The following is a description of a gene set: The larger of the two subunits of a ribosome. Two sites on the ribosomal large subunit are involved in translation, namely the aminoacyl site (A site) and peptidyl site (P site). species: Homo sapiens Human Gene Set: GOCC_LARGE_RIBOSOMAL_SUBUNIT, and this is the list of marker genes: RPLP2, MRPL19, RPL15, MRPL20, RPL30, RPL17, RPL7, RPL24, RPL27A, RPL23, RPL3L, RPL27, RPL26L1, RPL38, MRPL23, MRPL12, RPL4, RPL26, MRPL18, RBM3, RPL8, MRPL17, MRPL58, RPL36, RPL3, RPL19, MRPL40, MRPL24, MRPL10, MRPL9, RPLP0, MRPL50, RPL37, MRPL41, RPLP0P6, NPM1, MRPL53, MRPL45, NSUN3 (NOP2/Sun RNA methyltransferase 3), RPL14, MRPL54, RPL37A, MRPL46, ZCCHC17, MRPL3, RPL10A, RPL5, MRPL1, MRPL33, RPLP1, MRPL57, MRPL22, MRPL44, MRPL27, MRPL32, MRPL11, RPL13A, MRPL43, MTERF4 (NCBI Gene Id 130916), RPL18, GADD45GIP1 (NCBI Gene Id 90480), RPL41, MRPL36, MRPL15, MRPS18A, MRPL51, MRPL38, RPL36A, MRPL13, RPL39P5, MRPL30, RPL28, NSUN4, RPL10L, RPL12, MRPL39, RPL6, RPL22, RPL39, RPL7A, RPL35, MRPL37, RPL34, MRPS30, MRPL47, MRPL16, MRPL55 (mitochondrial ribosomal protein L55), MRPL35, RPL11, RPL35A, RPL32, MRPL34, RPL29, RPL31, MRPL4, RPL39L, MRPL21, MRPL48, MRPL14, RPL36AL (NCBI Gene Id 93632), RPL23A, MRPL49, RPL13, RPL7L1, RPL21, MRPL42, MRPL52, MRPL2, TIFAB, RPL37AP8 (NCBI Gene Id 649011), RPL9, UBA52, RPL18A, MRPL28, RPL10